Given this list of marker genes S100a8, Gstk1, Gpx4, Gpx2, Gpx5, Nxn, Ptgs2, Ptgs1, Apoa4, Trp53inp1, Dhfr, Cd36, Ambp, Apoe, Lpo, Ccs, Txnrd3, Gpx6, Gpx1, Sod3, Sod2, Gsta1, Hp, Fancc, Cp, Mt3, Ptges, Prdx3, Gpx3, Prdx5, Gstt1, Gsto1, Atp7a, Nfe2l2, Mb, Txn1, Mgst2, Srxn1, Gch1, Selenow, Selenos, Prdx6, Gpx8, Nos3, Txnrd1 (NCBI Gene Id 50493), Mgst3, Txndc17 (NCBI Gene Id 68102), Gsr, Prdx2, Ubiad1, Epx, Gpx7, Gsto2, Fabp1, Pxdn, Tpo, Nnt, Prdx6b, Cygb (cytoglobin), Prxl2b, Gstm7, Sesn2, Mpo, Kdm3b, Prdx1, S100a9 (S100 calcium binding protein A9 (calgranulin B)), Upk3bl, Sesn1, Park7, Selenot, Prxl2a, Apom, Txnrd2, Cat, Nqo1 (NAD(P)H dehydrogenase, quinone 1), Prdx4, Fbln5 (fibulin 5), Sod1, here is a description of the gene set: Any process carried out at the cellular level that reduces or removes the toxicity superoxide radicals or hydrogen peroxide. species: Mus musculus Mouse Gene Set: GOBP_CELLULAR_OXIDANT_DETOXIFICATION